Given this list of marker genes CTHRC1, GRHL2, STRIP2, IFNL1, UPB1, IL33, NOCT, SIGLECL1, SEC61G, CFB, GOLT1B, TNFSF8, CD40 (CD40 molecule), KDELR2, LMO7DN, IQCG, TOX3, PRSS23, EGR3, PDE4DIP, ZBTB32, NEMP1, PRDM9, HAUS5, MGAT2, C10orf95, ABCG1, MGC16275, WFDC2 (NCBI Gene Id 128489), BRPF3, CSF2, WARS1, TCF7L1, SERPINB1, SPAG9, COL5A3, ZNF300P1, LAMP3, PSMD5, FOXF1, UNC5C, MNS1, CYRIA, TFPI2, ZNF503, UBE2CP4 (NCBI Gene Id 283711), AK4, MYO10, OR13C4, SOCS2, BET1, SLC2A5, TPPP, ADAMTS10, LYRM1, POLR3C, DNAJA2, TAC3, NFE2L2, STK4, TPM2, JUN (NCBI Gene Id 3725), TTYH2, KLF4, POLRMTP1, SCHIP1, MMP10, PLEKHF2, UBB, PRPF40B, DPPA3, ANKRD28, OXTR, SLC38A4-AS1, RNF19A, WHRN, RALA, CNKSR3, MORF4L2, RAB11FIP1 (RAB11 family interacting protein 1), MGLL, CRADD, SIAH2, DENND4A, C17orf58, IDO2, RRN3 (NCBI Gene Id 92636), GUCY1B1, POPDC2, SERPINB7, BIRC3, F13B, LINC01588, CREB5, GPR157, RAB3IP, PIGA, SSR1, ARL5B, CDKN2A, PRODH2, ZFPM2, ENTHD1, PELI1, HSPA13, TNFRSF9, BCL2L14, SAR1A, TARP, UBE2E1, RAP1B, GADD45A, MAGT1, LINC02381, NRP2, BIRC2, SNHG15, TBC1D28, UBASH3A, MYLK, SLC1A3, MAMLD1, STAT4, ATP8B2, BTG3, TAB2, SCG3, SPSB4, TMED2, IL36G, LYSMD2, ALG2, MACROH2A2, GRB10, GBP5, HLA-DOB, GUCY1A1, MYO1A, HSD17B14, PBX4, NIM1K, LINC-PINT, UGP2, MAP4K4, CFLAR, ADPRH, NUDT11, PMAIP1 (NCBI Gene Id 9305), CCR7, CCDC159, RBM7, PRTN3 (proteinase 3), UAP1, PMCHL1, RAP2C, OSTC, CEP135, CADM1 (NCBI Gene Id 337934), TLCD3A, IL23A, GPBP1, PLS3, FNDC3A, MIR646HG, FAP, VWA8-AS1, IL15, MET, ZNF221, SELENOK, TVP23B, TCF24, TNFAIP3, CPNE8, TPBG, MIR155HG, JOSD1, DYRK3, RPS6KC1, TNFRSF11B, CAPN2, MAGIX, ESYT2, ARF4, IL12A, PPP4R2, HOMER1, CRLF2, LAD1, TENT2, CLUAP1, SYNE3, LINC00158, OSM, SLC25A37, DEPDC7, CLCF1, here is a description of the gene set: Genes down-regulated in comparison of dendritic cells (DC) stimulated with R848 at 8 h versus DCs stimulated with LPS (TLR4 agonist) and R848 for 8 h. from publication Napolitani G, Rinaldi A, Bertoni F, Sallusto F, Lanzavecchia A (PMID 15995707) Human Gene Set: GSE2706_R848_VS_R848_AND_LPS_8H_STIM_DC_DN Toll like receptors (TLRs) sense microbial products and initiate adaptive immune responses by activating dendritic cells (DCs). Since pathogens may contain several agonists we asked whether different TLRs may synergize in DC activation. We report that in human and mouse DC TLR3 or TLR4 potently synergize with TLR7, TLR8 or TLR9 in the induction of selected cytokine genes. Upon synergistic stimulation, IL-12, IL-23 and Delta-4 are induced at levels 50-100 fold higher than those induced by optimal concentrations of single agonists, leading to enhanced and sustained TH1 polarizing capacity. Using microarray analysis we show that only 1.5% of the transcripts induced by single TLR agonists are synergistically regulated by combinations of TLR4 and TLR8 agonists. These results identify a combinatorial code by which DCs discriminate pathogens and provide (suggest) a rationale to design adjuvants for TH1 responses. Series_overall_design: 3 untreated, 3 treated with LPS at 2h, 3 treated with LPS at 8h, 3 treated with R848 at 2h, 3 treated with R848 at 8h, 3 treated with LPS + R848 at 2h, 3 treated with LPS + R848 at 8h species: Homo sapiens